Given this list of marker genes PROC, AIFM2, F9, F2, F7, NQO1, F10, PROZ, VKORC1L1, VKORC1, UBIAD1, GGCX, PROS1, here is a description of the gene set: Human Gene Set: WP_VITAMIN_K_METABOLISM_AND_ACTIVATION_OF_DEPENDENT_PROTEINS species: Homo sapiens Vitamin K metabolism and activation of dependent proteins